The following is a description of a gene set: from publication Yevshin I, Sharipov R, Kolmykov S, Kondrakhin Y, Kolpakov F (PMID 30445619) Human Gene Set: ZNF558_TARGET_GENES Genes containing one or more binding sites for (ZNF558) in their promoter regions (TSS -1000,+100 bp) as identified by GTRD version 20.06 ChIP-seq harmonization. species: Homo sapiens, and this is the list of marker genes: LBX1-AS1, SYCE2, BMF, ANGPTL6, INTS5, TOR1A, NXPE3, TRAJ7, SLCO5A1, KDM3A, ADIPOR1P1, TRIM54, STAT6, SLCO5A1-AS1, GABPB2, MIR3162, ZSWIM8, ENPP3, SUZ12P1, CLTC, KCNK1, CCDC144BP, RPL32P27, WTAP, FCHO2, DDX5, GFM2, FBXO44, TBL1X, SLFN12, ISLR2, ESPN (espin), NR1H2, AURKB, DAPP1, RND1, GLI3, ZNF585A, NPAS4, ADGRL1-AS1, TTC1, RHOG, LHX8, SMG7, FRMD7, CBFA2T2, ZBTB8A, MAPK6, TFRC, ZNF833P, CCNI, HEBP2, ENSG00000266313 (novel transcript), FAM168A, KAT8, POR, NUCKS1, NSA2, MIR194-1, DPP9, EXOSC2, ZCCHC24, SMG7-AS1 (SMG7 antisense RNA 1), GBA1, MED21, FHL1, PPP1R26, WNT8A, AMPD3, ENOX1-AS1, LASP1, CHD4, CCT5P1, SUGP2, BRINP2, JMJD1C, CD160, HNRNPMP2, MIOS-DT, CYB5D2, SH2B3, KLHL20, WDR70, SESN2, TTI2, ZNF3, HIVEP3 (NCBI Gene Id 86368), UTS2B, WDR11, RASA4EP, TNFRSF19, FEM1C, FABP5P3 (fatty acid binding protein 5 pseudogene 3), PRKG1, ABR, TMEM259, RNF115, POLR3C, CCBE1, SLC25A16, CPEB2-DT, MTO1, FBXW7, RRN3P1, NUF2, MRPS31P4, CCL27, ZZEF1, INTS12, MECOM, CCNL1, PHF12, MB21D2, KRBA1, ADSS2, ZNF227, SRFBP1, SMG5, SNORA70, LINC00452, XKR8, ITGAL-AS1, ATF3, SMAD1, VPS51, MCF2L, TRIP6, FOXA3, GFI1B, EPCIP-AS1, MDM2, PPP5C, SNHG30, RNU6-2, RHOT1, WDR25, RGS5, PCBP3, MYPN, CDC42SE1, BRWD1, MED23, SMCHD1, NFATC4, LINC01775, ASCC1, TSC1, ENSG00000235480, TMEM79 (transmembrane protein 79), RHOBTB1, DDX46, LINC00649, GDI2, GIT2, RNU6-606P, CLDN23, SNORD13, ADA, GSTCD, OR1X5P, ENSG00000232995, LSG1, ZNF133, CCDC159, MTF2, PRECSIT, KRT18P45, CROCCP3, CEP128, KMT2D, KRT80, TMEM68, ENAH, CELF3, WWTR1, ARMT1, PMM1, SCAND3, COQ3, MIR548AW, DNAJC6, WEE2-AS1, NCKAP1L, IGF1R, GAPDHP22, RPL37, ACSF2, SLC37A4, ALKBH3-AS1, EPS8, GNAL, RNVU1-34, RNVU1-27, LIG4, ZNF461, PAXBP1, SEMA5B, CWC25, SPATS2L, TARS2, HMCN1, BMPER, TRIT1, SYMPK, PRKCI, RABGAP1L, MAN2A1-DT (NCBI Gene Id 124901041), QSER1, CEP95, NFKB1, SMARCD2, LINC01132, TTLL1, ARHGAP24, LINC02026, TNK2-AS1, PDZD2, NIP7P1, SLC44A1, RNF14P2, SSBP1, TRIM15 (tripartite motif containing 15), DMAP1, HAUS5, CDC42BPA, MBTPS2, SDC4, LINC00431, ZKSCAN2, ATP6V0A1, FES, SIAH1, SLC7A7, SCN3B, PRPS1P2, PEX16, WDR11-DT, ENSG00000265845, VPS39, FANK1-AS1, ADAR, NOL6, DNAJB6, ROBO2, ABHD13, MARS1, RNU6-7, NDC1, SNHG17, RAD52, CACYBP, MIR1273C, SACM1L, PLA2G15, CCT6B, H4C3, RBBP5, ZNF519P1, RNU7-90P, PPP6R1, HAUS5-DT, DYNC2I2, HAPLN2, PSMG4, MIR4645, NPM1P12, RMND1, MAN2A1, ZNF609, CCDC65, MRPS14, RPS26, STX4, PHIP, MIR4799, SRPK1, ALDOA, GLG1, RNA5SP146, GALNTL5, SEC22B, LUZP1, RPL27, GAPDHP14, BLCAP, MTFMT, SNIP1, ENSG00000244137, CASC3, GABARAPL1, KLHDC9, PCSK5, HNRNPA1P17, TMEM9, SF3A3, COPS3, CDCA3P1, CCDC124, ENSG00000212624, CCN2, MB, ALDH1A2, RPL22P21, RCAN1, FANK1, CDK4, INTS11, LOXL3, RPL23AP31, ZNF260, ZNF131, ZNF345, RNU11